The following is a description of a gene set: Human Gene Set: GOBP_POSITIVE_REGULATION_OF_PROTEIN_DEPOLYMERIZATION species: Homo sapiens Any process that activates or increases the frequency, rate or extent of protein depolymerization., and this is the list of marker genes: CFL2, STMN2, WDR1, CARMIL1 (NCBI Gene Id 55604), PDXP, AURKB, CARMIL2, NES, PLEK (NCBI Gene Id 5341), F2RL1, SPAST, CRACD, DSTN, SLN, VIL1, WASHC2C, TRPV4, SEMA5A, CFL1, ACTN2, KATNB1